The following is a description of a gene set: Syndactyly Webbing or fusion of the fingers or toes, involving soft parts only or including bone structure. Bony fusions are referred to as \bony\ syndactyly if the fusion occurs in a radio-ulnar axis. Fusions of bones of the fingers or toes in a proximo-distal axis are referred to as \symphalangism\. species: Homo sapiens Human Gene Set: HP_SYNDACTYLY, and this is the list of marker genes: CRKL, SALL4, PUF60, GJA1, AKT1, CTCF, DLL4, TBR1, EBP (EBP cholestenol delta-isomerase), IFT140, SLC12A2 (solute carrier family 12 member 2), TBX5, WNT7A, SNORD116-1, NARS1, PIBF1, FANCF (NCBI Gene Id 2188), TBC1D24, AP1G1, FANCG, FANCD2 (FA complementation group D2), RHOA (NCBI Gene Id 387), NXN, FLNB, LAMB3, CDAN1, TBX22, FDFT1, SLX4, HDAC4, LFNG (LFNG O-fucosylpeptide 3-beta-N-acetylglucosaminyltransferase), DLX6, ARL6, DYNC2H1, SUZ12, ROR2, CHRNG, NBAS, GRIP1, TMEM94, CTNND2, IL11RA, MEIS2 (NCBI Gene Id 56908), RAD51, POGZ, EPS15L1, MYH3, FZD2, FBXO11 (NCBI Gene Id 80204), RBM10, ZFX, SIK3, DLL3, MKRN3, H4C9, DSP, SNORD115-1, STAG1, BMP4, WASHC5, ADAMTS3, FILIP1, SETD5, UBA2, KIFBP, NEK1, CDKN1C, ESCO2, IFT52, SMC3, DACT1, CERT1, EFNB1 (ephrin B1), SMC1A, BLM, DHCR7, SYNGAP1, BRCA2, SYT1, PDE6D, PTDSS1, EBF3, PAX3, VPS13B, IFT172, IFT56 (intraflagellar transport 56), BBS2, SPECC1L, CEP120, IFT43, LTBP1 (NCBI Gene Id 4052), KIF7, EP300, PWRN1, ERI1, ALDH1A2, WLS, MYRF, TXNDC15, TRIM32, LMBR1, CACNA1C, TXNL4A, ATP9A (NCBI Gene Id 654090), CDH3, KCTD1, CUL4B, SMO, MKKS, NOTCH1, FANCC, ERCC4, DYNC2LI1 (NCBI Gene Id 51626), MAPKAPK5, MTRR, CEP55, UBE2T, CDH1, DLX5, TMEM216, ARMC9, MARS2, RPL10, RAB23 (RAB23, member RAS oncogene family), FBXW4, FGFR2, MYCN, BMP2, RTTN, DYNC2I2, HMGA2, PALB2, TAF6, VAC14, FAM149B1, NECTIN1, IRX5, WNT10B (Wnt family member 10B), CRIPT, GLI3, RFX7, BICRA, CCND2, FLII, CLCF1, PPP1R12A, FANCE, APC, KCNJ8, CKAP2L, NECTIN4, CEP295, MAD2L2, SMAD2, NOG, DOCK6, TMEM231, EN1 (NCBI Gene Id 2019), SHMT2, LZTFL1, BAP1, CHD2, CACNA1G, CSGALNACT1, SMARCAD1, SCAPER, RAD51C, DDX11, BRIP1, CCBE1, RBBP8, HDAC8, FANCI, HEPHL1, BMS1, CHUK (NCBI Gene Id 1147), SHANK3, ORC1, WNT5A, PSAT1 (phosphoserine aminotransferase 1), JUP, DEAF1, MAP3K20, BHLHA9, MEF2C, SLC25A24, BBIP1, DCHS1, EOGT, DVL1, IFT81, SATB1, CD96, MECP2, RIPPLY2, FANCL, SOX5, SEMA5A, TAF4, GNA11, VPS35L, FANCB, ZSWIM6, BCR, BBS10, UBE3A, REV3L, AP2M1, KDM6B, LIG4 (DNA ligase 4), KMT2B, RALA, FGFR1, KCNJ2, TBX15, CCNQ, FBXW11, PHIP, SCARF2, TGFBR2, BBS4, TCTN3, IRF6, SMAD4, ANKRD11, HERC2, WDR19, GABRA3, MAGEL2 (MAGE family member L2), TFAP2B, NAA10, TWIST1, BBS9, BBS1 (Bardet-Biedl syndrome 1), NEXMIF, TOPORS, FAT4, IFT74, IFT80, ARL6IP6 (ADP ribosylation factor like GTPase 6 interacting protein 6), DVL3, BLTP1, ITPR1, OFD1, SEPTIN9, SHH, EZH2, FRAS1, MEGF8, CFAP418, SLC2A1, PLEC, ZNF699, ZMIZ1, GNE, DYRK1A, PIGY, LMNA, DYNC2I1, PLAG1, FANCA, FGF10, MED13L, RERE (arginine-glutamic acid dipeptide repeats), FREM2, CNTNAP1, NIPBL, CHSY1, GDF5, TRAF7, APC2 (APC regulator of WNT signaling pathway 2), FANCM, SCLT1, CDIN1, CEP290, IKBKG, GPC3, MIR17HG, POLR3A, BTRC, B3GLCT, YY1AP1 (NCBI Gene Id 55249), KIAA0753, TRRAP, MAB21L2, MAN1B1 (NCBI Gene Id 51697), TTI2, SLC39A8, NR4A2 (NCBI Gene Id 4929), JARID2, BCOR, ARHGAP31, RAP1B, HOXD13, FGF9, ADNP, SCN1A, CPLANE1 (NCBI Gene Id 84157), LEMD3, FLI1, DDX59, H3-3A, MAPK1, CCDC28B, ASXL1, GPC4, BMPR1B, FLNA, TWIST2 (NCBI Gene Id 117581), TRIO, SETBP1, FGFR3, ZEB2, BBS7, WDPCP, NPHP1 (NCBI Gene Id 4867), RIPK4 (NCBI Gene Id 54101), RAI1, KMT2A, SF3B4, CEP19, ARCN1, TMEM53, PLAAT3, SBF1, PORCN (NCBI Gene Id 65017, porcupine O-acyltransferase), NEK9, CNOT2, ATP6V1B2, BBS5, MRPS28, DHODH, SMOC1, PHF21A, KDM5A, TRMT5 (NCBI Gene Id 57570), DPYSL5, SIN3A, NPAP1, PIK3CA, NSD1, RAD21, IFT27, SDCCAG8, DDX6, PRKD1, SCNM1, RBPJ, POLR3GL, LAMC2, NBN, PUM1, FBLN1, FGD1, HES7, ABCC9, CDH11, ITGB4, SEM1, RB1, SVBP, KCNJ5, MED12, MCTP2, NEDD4L, IFT122, PWAR1, SLC12A6, BBS12, NSDHL, CCDC22, LRP4, IQSEC2, GRB10, RBM8A, MKS1, NSUN2, SOST (sclerostin), LAMA3, PIEZO2, TTC21B, XYLT1, TTC8, FGF16 (fibroblast growth factor 16), CAMTA1, MYH8, TELO2, FERMT1, TBCK, SC5D, XRCC2, OTUD6B, SLC6A1, KAT6A, FIG4, CREBBP, PPP2R3C, PHGDH, WDR35 (WD repeat domain 35), HOXA11, CILK1, RFWD3, CTNND1, MED25, MESP2, IQCE, SALL1, CDC45, BRCA1, MECOM, PLXND1, BRD4, UBE2A, TP63, PNPLA6 (NCBI Gene Id 10908), IGF2, MAPRE2